Given this list of marker genes CLCA1, DYNLL1, REM2, PDLIM7, SLC48A1, CDCA5, BCL2L11, ETV5, KRTCAP2, TJP2, HNRNPAB, STMN1, ACOT9, REEP5, CASP12, KCNE3, MARVELD2, COQ8B, ENPP2, LSS, DNAJC12, MTA3, LOXL1 (NCBI Gene Id 4016), RPL12, TPMT, FPR2, KLC3, CD320, NKAIN4, ATXN10, LEPROTL1, CD34, NOL11, APEX2, CD151, CKLF, RRBP1, TESC, TGM2, BICC1, TP53RK, SCARB1, PCGF6, CCM2, SPON2, JPT1, APLN (apelin), MCM3, HES1, NKAPL, MMUT, FAM3C, TWF2, ILDR1, ITM2C, RFLNB, TRPC6, IGSF8, FBXO6, ITGA3, CHKA, SRD5A3, GREB1, PSMC1, AIPL1, ANO10, DEFB1, NEDD9, ARF3 (NCBI Gene Id 377), BCL10, MANSC1, MPP1, PLIN3, FAM181B, PIGC, PTPN21, SIDT1, CKAP4, LYPD3, HAUS7, LYVE1, PRKCA, CYP4F8, QTRT1, PLAU, NOPCHAP1, E2F3, MTAP, RAI14, FAM83G, PEA15, RFTN2, TRIB3, CDC20, CYP27B1, MFGE8, PYCR1, ARF6, CEP55, MSL2, CDK5R2, LHX8, NEBL, RARG, SCAMP5, FRRS1, RPH3A, RND3, NME6, CHCHD5, SCN1B, CORO1C, GNGT1, AS3MT, ACKR3, DBNDD2, NRGN, SRD5A2, IKBKE, SNCA, DHX9, HEXA, PRSS23, IQGAP3, TCF4, AGFG1, TUBB4B, RHBDF1, NLRP5, MTMR2, FKTN, ATF4, FAM110C, CD24, SLC6A8, GUSB, KRT18, UBD, COL4A1, AIG1 (androgen induced 1), STX18, SOX4, ATP6V0A1, YAP1, ABHD5, SPIC, BSND, APC, TFF2, ITPR3, CTPS1, SSTR2, EHMT2, SATB2, KIAA0930, ABHD8, SNX30, ARL2BP, DPP7, TUBA1B, AVPI1, TFRC, ALCAM, SMC4, SH3GL3, GPC6, PHGDH, UBE2S, ENC1, KLHL13, TRIM2, PITPNM1, CTPS2, TSPAN33, CLDN1 (NCBI Gene Id 9076), CSTB, NAPSA, SIRPA, KCTD17, TNK2, SH3GL2, C15orf39, BICD1, PHIP, TRIB2, TGFB2, C3orf52, PLPP2, MTF1, ERCC8, VASN, GGCT, CD9, IFNGR1, RP2, DEGS2, NEK6, FST, SLC2A3, F11R, SEMA4B, CD2AP, BCO1, DDIT4, PTPRE, COL3A1, HIP1R (huntingtin interacting protein 1 related), RNASE2, MAT2A, TUBA3D, KLF6, KIF11, TCEAL3, ENTPD2, LMNA, PVR, ABCG5, BOK, DCK, BMAL1, SLC41A3, KLHDC2, SPIRE2, CES2, PADI4, RELL1, SH3BGRL3, PDZD11, COL4A5, CLCNKB, OSGIN1, NAP1L1, TPD52, RBBP7, TOP2A, PLA1A, SECTM1, VASP, TMEM167A, PSPH, EPB41L4A, LPL (lipoprotein lipase), MAPK8IP1, ANXA4, SHROOM3, DNAJC5B, COL4A3, PAFAH1B3, ERCC3, IER5, SFXN4, LIMK1, CASP1, LOX, TOR2A, GNRHR, CRISP3, HIPK1, TMEM41B, NEK2, here is a description of the gene set: The molecular pathogenesis and the genetic aberrations that lead to the progression of hepatocellular carcinoma (HCC) are largely unknown. Here, we demonstrate that the thioredoxin interacting protein (Txnip) gene is a candidate tumor suppressor gene in vivo. We previously showed that the recombinant inbred congenic strain HcB-19 has a spontaneous mutation of the Txnip gene, and we now show that the strain has dramatically increased incidence of HCC, and that the HCC cosegregates with the Txnip mutation. Approximately 40% of the Txnip-deficient mice developed hepatic tumors with an increased prevalence in male mice. Visible tumors develop as early as 8 months of age. Histological analysis confirmed the morphology of HCC in the Txnip-deficient mice. Molecular markers of HCC, alpha-fetoprotein and p53, were increased in tumors of Txnip-deficient mice. The upregulation of p53 preceded tumor development; however, bromodeoxyuridine (BrdU) labeling of normal hepatic tissue of Txnip-deficient mice did not reveal increased cell proliferation. Finally, microarray analyses of tumor, non-tumor adjacent, and normal tissue of Txnip-deficient mice highlighted the genetic differences leading to the predisposition and onset of HCC. Our findings suggest that Txnip deficiency is sufficient to initiate HCC and suggest novel mechanisms in hepatocarcinogenesis. Human Gene Set: SHETH_LIVER_CANCER_VS_TXNIP_LOSS_PAM1 species: Mus musculus from publication Sheth SS, Bodnar JS, Ghazalpour A, Thipphavong CK, Tsutsumi S, Tward AD, Demant P, Kodama T, Aburatani H, Lusis AJ (PMID 16607285) Cluster PAM1: genes up-regulated in hepatocellular carcinoma (HCC) vs normal liver tissue from mice deficient for TXNIP.